The following is a description of a gene set: Human Gene Set: GOMF_WNT_RECEPTOR_ACTIVITY species: Homo sapiens Combining with a Wnt protein and transmitting the signal across the plasma membrane to initiate a change in cell activity., and this is the list of marker genes: LRP6, FZD6, FZD3, FZD5, FZD7, ROR1, FZD9, FZD8, PKD1, FZD4, TSPAN12, FZD10, RYK, FZD2, LRP5, FZD1